The following is a description of a gene set: The process where the cap structure, composed of a 7- methylguanosine (m7G) group and associated cap-binding proteins, located at the 5' end of an mRNA molecule, which serves as a molecular tag that marks the spot where the 40S ribosomal subunit, is recruited and will then scan in a 5' to 3' direction until an AUG codon is encountered in an appropriate sequence context to initiate mRNA translation. species: Mus musculus Mouse Gene Set: GOBP_CAP_DEPENDENT_TRANSLATIONAL_INITIATION, and this is the list of marker genes: Slbp, Pkp1, Nck1, Mif4gd, Eif3d, Ncbp2, Akt2 (thymoma viral proto-oncogene 2), Ncbp1